The following is a description of a gene set: studied in species Homo sapiens from publication Yevshin I, Sharipov R, Kolmykov S, Kondrakhin Y, Kolpakov F (PMID 30445619) Human Gene Set: MIER1_TARGET_GENES Genes containing one or more binding sites for (MIER1) in their promoter regions (TSS -1000,+100 bp) as identified by GTRD version 20.06 ChIP-seq harmonization., and this is the list of marker genes: HNRNPAB, RCC1L, FZD2, KCNN4, PPM1N, AP3B2, HTR1A, OSER1-DT, ACAP3, RNA5SP243 (RNA, 5S ribosomal pseudogene 243), RUNDC3A-AS1, HDDC2, CTXN2, BRD4, ENSG00000260830, RUNDC3A, FAM20B, CHST10, LTBP3, VGF, TSEN54, GSE1, CENPN, B3GNT2, ENSG00000259755, DAPK3, EFHB, FGF18 (fibroblast growth factor 18), SLC4A1AP, BDNF, CRYBA2, SLC39A3, FCHSD2, CA10, SCGN, BST2, RPH3A, CIMIP5, RTN4R, HNF4A-AS1, LACTB2, P3H3, OSER1, WIZ, ANKRD13A, VIM-AS1, ECM1, WDR90, GRM2, PAQR4, SCAMP5, FGF12-AS2, TRIM69, RNFT2, NRXN2, ALB, TNRC18, CHCHD4, SCG3, TCP11L2, BICDL1, ATP6V1B2, CLSTN3, FAM53C, CMC2, CLIC4P2, GDF11, TRAK1, YIF1A, TRIP10, STK35 (NCBI Gene Id 140901), HHATL, TPH2, SLC8A2, WRAP53, RNA5SP242, MIR551A, HLA-E, STXBP5L, MIR9-3HG, DAXX, ADGRG1, RFPL1S, ETFDH, OGDHL, C4orf46, ACTL6B, SYT14, C17orf58, KLHDC9, MAST4-AS1, CCDC71, ARFGEF2 (NCBI Gene Id 10564), PIK3R3, UTP4, VIP, FZD1 (NCBI Gene Id 8321), BTN2A1, ACVR2A, DGKD, KCNH6, AQR, VTN, RAB39A, SVOP, NKAIN1, KCNK12, LHFPL5, HTR5A, BRD7, PLA2G4C, SERBP1P3, PITPNC1, TTC9B, NSG2, VPS54, MEF2A, MAST4, PTCH1, KCNC1, FBLL1, LTBP4, KCNB1, UBE4B, SIGLEC30P, GFPT2, UBR3, SSBP2, MVB12A, ANXA2R, CARTPT, KCNIP1-AS1, KSR1, CCDC136, SEZ6L2, HEMK1, ICMT-DT, OR1AB1P, FAM222A-AS1, MAPK8IP2, SSBP1, PHF21A, RN7SKP92, MDGA1, ZNRF3, ZNF579, MAD2L1BP, DNER (delta/notch like EGF repeat containing), CABP1-DT, CCN1, KCNH2, UBE2I, KBTBD4, GLRA1, SMAP2, PDE4C, PUS3, TMEM179, GDAP1L1, SSH1, YBX1P7, XKR9, LRRC20, MAPK11, HEXIM1, TNR-IT1, MIR1224, LINC00964, PHC2, VRK3, CASKIN2, CTDSP1, IQCN, CLK2, TFAP4, NKAPD1, TKT, SLC16A5, TRPC7, NEUROD4, NYAP2, CDK5RAP1, CA15P1, LINC01586, BTN2A2, PSPC1, CACNG2, KCNC4, MRPS6, GRM1, SIRT4, GDAP1, ANKRD23, PRSS27, MANEAL, VIM, GNB2, CELF3, CNTNAP5, RPS29P25, PGBD5 (piggyBac transposable element derived 5), RNA5SP60, GNAS, PIH1D2, RNVU1-26, CDC37, IFI6, MIR7-3HG, BSG, DPF1, CADPS, SLC35E2A, RPL23AP71, KCNQ2, CNTNAP5-DT, TMEM181 (transmembrane protein 181), PARD6A, ECSIT, NMBR, CACNG2-DT, BAHCC1, HS3ST2, SCRT2, LINC00485, BISPR, SS18, STMN3, ASPHD1, PKMYT1, MOGS, SCGB2A1, PSD, HRH3, DUSP7, PRLHR, ZNF280B, SYT5, SYT7, SCML2, HHATL-AS1, CRMP1, CNIH2, ZDHHC24, DIABLO, FAM237A, NALF1, GPR19, ANKRD34C-AS1, GALNT11, PCSK1, SEMA3B, GSX1, BARHL1 (NCBI Gene Id 56751), RAC1, RPL18A, SGSM1 (small G protein signaling modulator 1), CTXN2-AS1, GPR108, IGSF10, AKAIN1, SUPT7L, RXFP3, FAM89A, NPPB, CHST8, KRT10, SLC5A3, ATP13A2, NECAB2, CHD9NB, MARF1, SMG8, VPS37D, SPICP4, CHGB, ADAR, MFSD12, ADAMTSL5, TBC1D10A, SLC35F2, IGFL4, SRRM3, TMEM120B, TCF3, SNAP25-AS1, GPR6, CHRNA4, CCDC159, SP8, ACD, PTP4A2, HSPG2, ADGRB3, SULT2B1, ZNF275, SYP, C3orf18, FCMR, NR4A1, ADAM29, KRT86, HSPD1P12, P2RX6, BSX, RXRB, NOS2P4, SLC35F1, CADM3-AS1, SEZ6, PYGM, SLC25A13, DLG4, MAST3 (NCBI Gene Id 23031), RESP18, ZCCHC24, SCG2, MARCHF4, ANKRD24, EMC9, ADCYAP1, CTDSP2, NDUFS3, LHFPL4, MYO1A, RIMBP3, GIT1, SLC12A1, CRIP2, PAOX, ANAPC11, RIMKLA, CPLX2 (complexin 2, NCBI Gene Id 84242), NPDC1, FBXL15, SMARCE1P6, TJP3, DDX25 (DEAD-box helicase 25), SYN1, CCDC13, VSTM2L, SCRT1, CDK5RAP2, DNMT3A, CALB1, NRSN2, SUPT16H, CYB5R4, ACSL6, ARSA, WEE2-AS1, CMIP, TMEM145, GGT1, OSBP2, CELF6, DISP3, NRSN2-AS1, VWA5B2, ENSG00000229797, CDH23 (cadherin related 23), UNC80, LINC00526, GPR158 (NCBI Gene Id 57512), CNTNAP2, ICMT, WDR24, GFI1B, DAO, MADCAM1, DRD3, EVA1B, MIR7-3, EXOC3L1, RHBDF1, NXPH1, UBE2V1P4